The following is a description of a gene set: Human Gene Set: GSE7218_UNSTIM_VS_ANTIGEN_STIM_THROUGH_IGM_BCELL_UP studied in species Homo sapiens Genes up-regulated in B lymphocytes expressing IgM - BCR: untreated versus anti-HEL. IgG cytoplasmic tail interferes with the induction of antigen-response genes from publication Horikawa K, Martin SW, Pogue SL, Silver K, Peng K, Takatsu K, Goodnow CC (PMID 17420266), and this is the list of marker genes: LRRC55, ALDH1L2, PGF, AVIL, PDLIM7, TTLL9 (tubulin tyrosine ligase like 9), ANKRD11, FBXO31 (F-box protein 31), KIF2B, DYRK3, PRND, ATP7B, GASK1A, TGM3, TMEM174, SLC27A4, GBGT1, PDE6H, GPR182, KRTAP6-1, TEKTL1, ST3GAL2, DNTTIP1, HSD17B10, FSD1, SAMD3, INPPL1, PLPP7, CDYL, PMM1, TKTL1, PTGES, PHRF1, RNF128, AIRN, PLAC1 (NCBI Gene Id 10761), TCAF1, SFMBT1 (NCBI Gene Id 51460), MIR182, GMIP, BICC1, MIR363, GAN, ARHGAP24, KRT6A, CRX, SOAT1, MMP20, TRIB1, HPS1 (NCBI Gene Id 3257), SOX12, STAC2, PLEKHG5, SKIL, MFAP3L, FGF16, DPP10, ARL16, LIPK, SCIN, ZC3H10, KLF13, MEIS3, PLPP4, TM4SF20, GUCA1A, TENT4B, IL18RAP, PLPP1, GLCE, LBX1, CLIP2, PTGFRN, FANK1, RNF112, GRIN2A, HYAL6P, WDR59, STX1A, SBF1, OSBPL5, NKIRAS1 (NFKB inhibitor interacting Ras like 1), NMS, CRABP1, EFCAB10, MIR653, CBR3, TFF3, NUDT21, CTXN2 (cortexin 2), CCDC28B, CTSA, LINGO1, SGCD, PRSS33, CD72, BHLHA9, STT3B, TMEM121, FZD5, RDH16, SRP68, PSMD8, TTC21A, MRPL9, GAS8, FOS, RNF166, KCNK2, IL33, FOSB, NFKBID, AMIGO3, SERPINB5, DNAJC27, GALR1, GP2, KDM4D, SMC1B, AP2A2, VWF, TRIM58, CLEC4G, KDELR3, RUSC1, EMX2, IER5L